Given this list of marker genes EXT2, P3H1, WNT7A, PHF21A, RUNX2, TAPT1, IFT43, THPO, ZMPSTE24, HDAC6, SEC23A, CREB3L1, SERPINH1, BMPER, LAMA5, LMNA, LBR, VAC14, SLC25A19, FIG4, PPIB, COL1A1, COL1A2, PPP3CA, TRIP11, FGFR2, FAM111A, CRTAP, INTU (inturned planar cell polarity protein), ALG9, TBCE, TXNDC15, SLC25A24, ALX4, MPL, ALPL, ANTXR1, COL2A1, NOTCH2, here is a description of the gene set: species: Homo sapiens Human Gene Set: HP_DECREASED_SKULL_OSSIFICATION A reduction in the magnitude or amount of ossification of the skull. Decreased skull ossification